Given this list of marker genes PPP2CB, ORC6, ORC1, CCNB1 (NCBI Gene Id 891), POLA2, PRIM2, TFDP1, ORC2, ORC3, POLA1 (NCBI Gene Id 5422), PPP2R3B, PRIM1 (DNA primase subunit 1), TFDP2, RB1, PPP2R1B, PPP2R1A, ORC4, MCM8, CDK1, PPP2CA, ORC5, E2F1, here is a description of the gene set: species: Homo sapiens E2F mediated regulation of DNA replication Human Gene Set: REACTOME_E2F_MEDIATED_REGULATION_OF_DNA_REPLICATION